The following is a description of a gene set: Human Gene Set: HP_MITOCHONDRIAL_INHERITANCE species: Homo sapiens A mode of inheritance that is observed for traits related to a gene encoded on the mitochondrial genome. Because the mitochondrial genome is essentially always maternally inherited, a mitochondrial condition can only be transmitted by females, although the condition can affect both sexes. The proportion of mutant mitochondria can vary (heteroplasmy). Mitochondrial inheritance, and this is the list of marker genes: MT-ATP6, MT-ND4L, MT-TQ, FDX2, MT-TW, MT-TV (mitochondrially encoded tRNA-Val (GUN)), MT-TP, MT-TN, MT-CO3, MT-CYB, MT-ND1, MT-TS2, MT-TL1, MT-ND2, MT-ND5, BCS1L, SURF1, MT-ND6, MT-TF, MT-CO2, MT-TC, TRMU (NCBI Gene Id 55687), MT-TK, MT-TI, MT-TT, MT-ND4 (mitochondrially encoded NADH:ubiquinone oxidoreductase core subunit 4), MT-CO1, NDUFS4